The following is a description of a gene set: studied in species Homo sapiens Human Gene Set: GOMF_UBIQUITIN_LIKE_PROTEIN_BINDING Binding to a small conjugating protein such as ubiquitin or a ubiquitin-like protein., and this is the list of marker genes: STAM, DNAJB2, NBR1, SMARCAD1, UBE2N, DCUN1D5, MVB12B, RNF168, OTULINL, TNFAIP3, TOM1L2, DCUN1D3, MARK4, UBAP1, GGA2 (golgi associated, gamma adaptin ear containing, ARF binding protein 2), TP53INP2, UBXN2B, CXCR4, UEVLD, CKS2, OTUB1, ASCC2, NPLOC4, USP33, ILRUN, UCHL3, DCUN1D2, TOP2A, USP13, DDI2, RBCK1, RNF111, TOLLIP, MDM2, NOD1, UCHL1, UBA2, STAM2, UBAP1L, TOM1L1, UBXN10, FBXW7, UBXN1, AUP1, TAB2, RNF4 (ring finger protein 4), KLF1, TRIM32, RNF19B, RAD23A, CASP8AP2, DCUN1D4, SMAD3, UBXN11, FAF2, CUEDC1, HABP4, USP5, TSG101, NEDD4, RNF185, NUP62, SPRTN, USP25, UBXN2A, UBE2L6, UBXN7, GGA1, DHX16, GGA3, VPS28, USPL1, SQSTM1, SIRT2, AMFR, TOM1, SIMC1, NOD2, MAP3K7, UBXN8, OTUB2, RNFT1, FBXO7, JARID2, PML (NCBI Gene Id 5371), HERC2, VPS36, RNF31, UBR5, BUB3, DNAAF10, IKBKG, SOBP, PELP1, CUEDC2 (NCBI Gene Id 79004), NSFL1C, PRKN, SHARPIN, WDR48, TAB3, FAAP20, CBX4, CKS1B, N4BP2, FAF1, EPS15, ZFAND2B, MARCHF7, RNF8, GCNA, HDAC6, HGS, N4BP1, TDG, USP16, SERBP1, RAD23B, RAE1, MVB12A, BIRC2, HSPB1, DCUN1D1, PLAA, UBE2A